Given this list of marker genes WDTC1, ADCY10, PGK1, ATF3, SDHAF3, PPARA, ZFP92, PPP1CA, RANBP2 (RAN binding protein 2), TPI1, BRS3, KCNQ1, ENO1, SIK1, LCMT1, NR0B1, PRKACA, SERPINA12, HECTD4, DYRK2, GAPDH, HK1, EP300, ERRFI1, ALDOC, DLAT, MST1, GOT1, SLC45A3, ADPGK, OMA1, GNMT, MIR210, FBN1, PDK4, SORD, ENO2, SDS, SLC39A14, LRP5, OAS1, G6PC2, NCOA2, BCKDK, DGKQ, ATF4, USP7, CRTC2, LDHA, PPARGC1A, PTPN2 (protein tyrosine phosphatase non-receptor type 2), MLYCD, SORBS1, GPD1, RBP4, USF1, HK3, DDB1, OGT, GDPGP1, BAD, SLC25A13, SLC25A11, PCK1, SIRT7, GALM, PFKM, PDHA2, GAA, PGAM2, PRKAG2, IRS2, C1QTNF3, G6PC3, GCK, ACTN3, FOXK1, DGAT2, GCG, ADIPOR1, DCXR, PRKAG1, BCL2L13, IRS1, SESN2, MIR107, PPARD, BRAT1, PGM2, TIGAR, PDHB, ZMPSTE24, FAM3A, GPLD1 (glycosylphosphatidylinositol specific phospholipase D1), PRKN, TFF3, PFKFB1, PDK1, C1QTNF12, PGK2, SIRT1, INSR, MIR103A1, PPP1R3E, PCK2, CRY1, TCF7L2, GPI (NCBI Gene Id 2821), PIK3CA, PMAIP1, ADIPOQ, FABP5, IGF1, SLC37A4, PDK2, TFAP2B, KBTBD2, G6PC1, LIPA, G6PD, PC, PER2, CPT1A, KCNJ11, SLC35B4 (solute carrier family 35 member B4), KAT2B, C1QTNF1, NPY1R, ONECUT1, ACADM, NNMT, RORA, PPP4R3A, PGM1, SERP1, PGM2L1, FOXK2, HMGB1, ARPP19, LEP, PFKFB2, WDR5 (NCBI Gene Id 11091), PFKP, CLK2, NR3C1, PDHA1, NLN, FBP1, TP53, ALDOB, AKT1, FOXO1, GSK3A, RORC, PHKG2 (phosphorylase kinase catalytic subunit gamma 2), HK2, NFE2L1, ENO3, ACACB, GHRL, SIRT6, PGP, KAT2A, PFKL, PPP1R3B, PRKAG3, IGFBP4, ERFE, AKT2, HKDC1, PGAM1 (NCBI Gene Id 95038), BOLA3, PDK3, MDH2, APOD, PRKAA1, ZNF692, IGFBP3, PPP1R3G, SELENOS, MAPK14 (NCBI Gene Id 1432), H6PD, PKM, PDX1, MTCL2, PTH, GPD2, EPM2AIP1 (NCBI Gene Id 9852), GNB3, GAPDHS, PHKA1, TKTL1, SLC25A10, INS, TNF, IGF2, PPP4R3B, INPPL1, LEPR, FBP2, here is a description of the gene set: The chemical reactions and pathways involving glucose, the aldohexose gluco-hexose. D-glucose is dextrorotatory and is sometimes known as dextrose; it is an important source of energy for living organisms and is found free as well as combined in homo- and hetero-oligosaccharides and polysaccharides. Human Gene Set: GOBP_GLUCOSE_METABOLIC_PROCESS studied in species Homo sapiens